The following is a description of a gene set: Human Gene Set: GOBP_REGULATION_OF_RESPIRATORY_BURST_INVOLVED_IN_INFLAMMATORY_RESPONSE Any process that modulates the rate, frequency or extent of a phase of elevated metabolic activity, during which oxygen consumption increases made as a defense response; this leads to the production, by an NADH dependent system, of hydrogen peroxide (H2O2), superoxide anions and hydroxyl radicals. species: Homo sapiens, and this is the list of marker genes: NCF1, DUSP10, INS, LBP, RPS19, GRN, SLAMF8, S100A9